Given this list of marker genes LCP2, ZNF117, TP63, PRKAA1, CXCL12, MNDA, STAT2, DLEC1, PPP1R8, NKG7, IFNAR1, UPK3A, PIK3CG, ARFIP1, DYRK2, RGS19, CRIPTO3, PCDHB17P, NFE2, PAGE1, RHOH, MTMR11, PF4, here is a description of the gene set: from publication Hofmann WK, de Vos S, Komor M, Hoelzer D, Wachsman W, Koeffler HP (PMID 12411319) Genes down-regulated in bone marrow hematopoietic stem cells (HSC, CD34+) from patients with high risk of myelodysplastic syndrom (MDS) compared to the low risk patients. Gene patterns of expression in purified CD34(+) bone marrow cells from 7 patients with low-risk myelodysplastic syndrome (MDS) and 4 patients with high-risk MDS were compared with expression data from CD34(+) bone marrow cells from 4 healthy control subjects. CD34(+) cells were isolated by magnetic cell separation, and high-density oligonucleotide microarray analysis was performed. For confirmation, the expression of selected genes was analyzed by real-time polymerase chain reaction. Class membership prediction analysis selected genes. Using the expression profile of these genes, we were able to discriminate patients with low-risk from patients with high-risk MDS and both patient groups from the control group by hierarchical clustering (Spearman confidence). The power of these genes was verified by applying the algorithm to an unknown test set containing expression data from 8 additional patients with MDS (3 at low risk, 5 at high risk). Patients at low risk could be distinguished from those at high risk by clustering analysis. In low-risk MDS, we found that the retinoic-acid-induced gene (RAI3), the radiation-inducible, immediate-early response gene (IEX1), and the stress-induced phosphoprotein 1 (STIP1) were down-regulated. These data suggest that CD34(+) cells from patients with low-risk MDS lack defensive proteins, resulting in their susceptibility to cell damage. In summary, we propose that gene expression profiling may have clinical relevance for risk evaluation in MDS at the time of initial diagnosis. Furthermore, this study provides evidence that in MDS, hematopoietic stem cells accumulate defects that prevent normal hematopoiesis. studied in species Homo sapiens Human Gene Set: HOFMANN_MYELODYSPLASTIC_SYNDROM_RISK_DN